The following is a description of a gene set: Human Gene Set: GOLDRATH_EFF_VS_MEMORY_CD8_TCELL_UP The only cells of the hematopoietic system that undergo self-renewal for the lifetime of the organism are long-term hematopoietic stem cells and memory T and B cells. To determine whether there is a shared transcriptional program among these self-renewing populations, we first compared the gene-expression profiles of naïve, effector and memory CD8(+) T cells with those of long-term hematopoietic stem cells, short-term hematopoietic stem cells, and lineage-committed progenitors. Transcripts augmented in memory CD8(+) T cells relative to naïve and effector T cells were selectively enriched in long-term hematopoietic stem cells and were progressively lost in their short-term and lineage-committed counterparts. Furthermore, transcripts selectively decreased in memory CD8(+) T cells were selectively down-regulated in long-term hematopoietic stem cells and progressively increased with differentiation. To confirm that this pattern was a general property of immunologic memory, we turned to independently generated gene expression profiles of memory, naïve, germinal center, and plasma B cells. Once again, memory-enriched and -depleted transcripts were also appropriately augmented and diminished in long-term hematopoietic stem cells, and their expression correlated with progressive loss of self-renewal function. Thus, there appears to be a common signature of both up- and down-regulated transcripts shared between memory T cells, memory B cells, and long-term hematopoietic stem cells. This signature was not consistently enriched in neural or embryonic stem cell populations and, therefore, appears to be restricted to the hematopoeitic system. These observations provide evidence that the shared phenotype of self-renewal in the hematopoietic system is linked at the molecular level. from publication Luckey CJ, Bhattacharya D, Goldrath AW, Weissman IL, Benoist C, Mathis D (PMID 16492737) studied in species Homo sapiens Genes up-regulated in comparison of effector CD8 T cells versus memory CD8 T cells., and this is the list of marker genes: LITAF, AK3 (adenylate kinase 3), TACC3, CCNB2, UCHL5, TUBA1A, PRIM1, SIVA1, RAD51AP1, TMEM50B, LIG1, ATP6V1A, CMC2, FPR2, CBX1 (NCBI Gene Id 10951), LSP1 (NCBI Gene Id 4046), SNX10, S100A4, SUN1, TUBA1C, EMP3, DUSP2, EGR1, TMPO, TOP2A, BIRC5, CD99, PDCD1, CA2, PCLAF, RNASEH2B, TSPAN32, CDC45, H1-0, NUDT4, KIF2C, AURKB, TCF19, GZMA, MIS18BP1, GEM, IFNG, TYROBP, CISD1, EMP1, TKTL1, SMARCC1, TMEM97, MT1E, TUBA1B, MYADM, CLCN5, GGH, BATF3 (basic leucine zipper ATF-like transcription factor 3), H2AX, VPS45, KIF11, H2AZ1, MKI67, DHFR, C3, CDK1, DTL (NCBI Gene Id 51514), LAG3, ANXA1, EZH2, CHAF1A, ROM1, SUZ12, DLGAP5, ANLN, HP, RAN, MAD2L1, LMNB1, PSMA5, IFI27L2 (NCBI Gene Id 83982), CDKN2C, KIF20A, E2F8, RBL1, F2RL3, TTK, TAGLN2, TK1 (thymidine kinase 1), SYCE2, SYPL1, PERP, CDKN3, BHLHE40, RRM2, RFC5, CCNF, CAPG (capping actin protein, gelsolin like), MRPL18, UBE2T (NCBI Gene Id 29089), DHRS1, S100A10, ECT2, NRP1, MPEG1, MTM1, IRF8, INCENP (inner centromere protein), BRCA1, DCK, KIF4A, CD244, DEGS1, RRM1, NEK2, CDCA8, HMGB3, PRDX4, TYMS, UBE2N, GZMB, FDFT1, MCM10, CENPA, STMN1, BUB1, FANCM (NCBI Gene Id 57697), ASF1B, LGALS1, STT3B, IFITM3 (NCBI Gene Id 10410), KPNA2, H3-4, TXN, SNX3, GZMK, TUBB3, YBX3, SERPINB9, ASPM, ITGAX, SMC2, DOCK5, TMEM14C, RHD, S100A8, PLK4, NFYB, DNA2, CASP3, WEE1, RAD51, AURKA, NR4A1, FGL2, MAPK6, IQGAP3, LYN, CKS2, PLAC8, LGALS3, ANXA4, CDC20, ADAM8, CCNA2, GABARAPL1, CKS1B, KIF22, XBP1, DNAJC1, UCK2, CIP2A, TIPIN, MT2A, NDRG1, PDK3, CDCA3, LXN, NUSAP1, CDC6, POLA1, ANXA2, GTF2B, CHEK1, POLE2, CKAP5, ISG20, GALNT3, CDC25C, GMNN, KLRG1, ATP5IF1, SQLE, SPDL1, KIF23, CRMP1 (NCBI Gene Id 1400), IRF4, NCAPH, FKBP5, PRC1, CCR2, DBI, NUP62, IDI1 (NCBI Gene Id 3422)